Given this list of marker genes MIR181D, SH3RF1, MAP2K3, MAP2K6, KSR1, MAPK8IP3 (NCBI Gene Id 89855), ICAM1, MIR181B1, ADRA1B, FGF18, MINK1, MAP3K12, CRACR2A, DRD2, PLA2G1B, TPBG, FGF3, SASH1, FGG, MBIP, TENM1, PELI2, LYN, XIAP, UNC5CL, ANKRD6, WNT7A, ADRA2C, PLCG2, LTBR (lymphotoxin beta receptor), KLHDC10, FFAR4, TNIK, NOX1, SPRY2, ABCA7, C1QTNF1, MIR23A (microRNA 23a), TP73, MOS, NTF3, APOE, LPAR1, PDE6H, FGF4, TREM2, NRG1, ITGB3, GLIPR2, HTR2C, RB1CC1, RAMP3, NKD1, TRAF2, TLR4, NDST1, CHI3L1, CIB1, HLA-DRB1, MAP3K4, CTNNB1, FZD7, MIR519D, ZC3H12A, SHC1, EGFR, SH3RF2, CSF1R, GPNMB, S100A7, NOTCH2, TBX1, EDN3, GAS6 (NCBI Gene Id 2621), DNAJC27, MYD88, CDC42, LAT, MAP2K1, CCDC88C, EFNA1, MYOC, PLCB1, ACTA2, NOD1 (NCBI Gene Id 10392), ROCK2, SPAG9 (sperm associated antigen 9), DUSP19, TRAF6, FGFR1, C5AR1, SDCBP, PHB2, TLR6, DAB2IP, DVL3, CRK, IL1B (NCBI Gene Id 3553), INHBA, VEGFA, MIR92A1, TAOK3, KL, RAF1, MAPKBP1, F2RL1, HTR2A, ROBO1, CLEC7A, CCL3, CX3CL1, APELA, KSR2, GRM1, MYDGF, PDCD10, MIR21, RELL2, CD81, CCL21, CD44, IGF1R, SOD1, EGF, IGFBP3, BMPER (BMP binding endothelial regulator), FBXW7, RIPK2, DUSP15, PECAM1, TGFA, AKAP12, TNFRSF19, GNAI2, OPRM1, NRP1, BNIP2, ADAM9, CDH2 (cadherin 2), ADRB2, MAPK8IP1, IL6R, TGFB1, PIK3R5, SEMA4C, FGF23, FGF5, PRXL2C, NOTCH1, MAP3K5, TRAF4 (NCBI Gene Id 9618, TNF receptor associated factor 4), FCRL3, NODAL, IGF2, IGFBP4, MIR181A2, GFRAL, CRIPTO, MIR24-1, PROK1, RYK, FLT1, HTR2B, SLC30A10, MAP3K7, GPR37L1 (NCBI Gene Id 9283), GCNT2, CCN2, AVPR1B, FRS2, GPR55 (NCBI Gene Id 9290), RASGRF1, LGALS9, AVPI1, PRKCE, SPI1, LAPTM5 (lysosomal protein transmembrane 5), GHRL, NTRK2, NR2C2, FPR2, PLA2G5, LEP, FGF22, TRIM5, HAND2, LAMTOR2, TAB1, SYK, FGF21, BMP2, AGER, GH1, TIRAP, PDGFRB, EPO, VEGFB, CRKL, ROCK1, GADD45B, GPER1, ALKAL2, FGF20, MAPK8IP2, NENF, PDGFRA, MEF2C, CD74, TEK, FGF19, PRMT1, PIK3R6, ALOX12B, SRC, RASSF2, RAPGEF2, LPAR3, PYCARD, FSHR, NPNT, BCAR3, GSDME, NPY5R, MAP3K11, MTURN, OSM, FGFR3, NOD2, ELANE, AXIN1, MIR27A, ERBB3, FGF16, KLB, APP, CD36, ADRB3, FZD10, DIRAS1, PRKCA, IL26, ITGA1, ERBB2, ALOX15, FCGR2B, FGF10, SEMA3A, ZNF622, CFLAR, GPR183, PPIA, ANGPT1, TGFB2, LPAR2, SLCO3A1 (solute carrier organic anion transporter family member 3A1), MST1R, IL6, RELL1, NECAB2, FGF7, PTPN22, GCG, LRRK2, JAK2, LIF, ERP29, FGFR2, WNT4, S100A12, DHX33, ADRA2B, PDGFD, SERPINF2, FGA, PTPN11 (protein tyrosine phosphatase non-receptor type 11), CCR1 (NCBI Gene Id 1230), LILRA5, CCR7, PRKD2, SH3RF3, EPGN, WNT7B, CDK10, TAOK1 (TAO kinase 1), DVL2, NOX4, CSPG4, NTRK1, ADRA2A, HMGB1, MAP4K2, THPO, IQGAP1, FGF9, STK39, NDRG4, AR, TNFAIP8L3, MADD, SOX2, DUSP22, NMNAT1, WNT5A, DRD5, NRK, IL34, CXCL17, PTPN1 (protein tyrosine phosphatase non-receptor type 1), PRKCZ, IGFBP6, SEMA7A, DOK4, HCRTR1, MFHAS1, EDN1 (NCBI Gene Id 1906), TNFSF11, FLT4, DDR2, INSR, MARCO (macrophage receptor with collagenous structure), P2RY1, CD27, TNF, RNF13, TRAF7, FGF6, GADD45A, HAVCR2, MAPK3, TPD52L1, WWC1, INAVA, MIR27B, MAP2K7, JUN, FGF2, CALCR, IAPP, RASGRP1, TLR3, IL11, LAMTOR1, FGB (fibrinogen beta chain, NCBI Gene Id 2244), ERN1, WNT16, PRDX2, PDGFB, TMEM106A, MT3, DOK5, FLT3, DENND2B, GPBAR1 (G protein-coupled bile acid receptor 1), NELFE, BRAF (B-Raf proto-oncogene, serine/threonine kinase), BIRC7, ADRA1D, TRPV4, PTPRJ, EDA2R, ADAM8, KDR, SYT14P1, EIF2AK2, NAIP, EZH2, SCIMP, MAP3K3, PHB1, ACKR3, TLR9, ARRB1, INS, SLAMF1, NPY (neuropeptide Y), CAVIN3, TAOK2, EPHA8, SPHK1, JCAD, PDGFC, CCL19, RAP1A, GRM5, RAP1B, CDON, CARTPT, DRD1, MAP4K1, OR2AT4, FGF17, ARHGEF5, RIT2 (Ras like without CAAX 2), HGF, ARRB2, STK3, MAP3K10, HIPK2, PJA2 (praja ring finger ubiquitin ligase 2), GHR, DRD4, MIR126, BMP4, GAREM1, NPSR1, PLA2G2A, NTRK3, PDE6G, F2R, FGF1, IGF1, MIF, GPR37, LAMTOR3, PTK2B, DSC2, OPRK1, PDGFA, PTPRC, RET, PDE8B, GDF6, ADRB1, EDAR, CASR (calcium sensing receptor), ADORA2A, ADORA1 (adenosine A1 receptor), KIT, GDF15, EPHA4, GADD45G, CHRNA7, GRM4, PDE8A, ADCYAP1 (NCBI Gene Id 116), P2RX7, HRAS, ABL1, ARHGAP8, PIK3CG, FGFR4, FGF8, FERMT2, MIRLET7B, RIPK1, CAV2, MID1, CD4, ARL6IP5, CARD9, GPR101, BANK1, TNFRSF11A, DIRAS2, IQGAP3, STK25, DKK1, P2RY6, NGF, THBS1, DDT, NAMPT, ADRA1A, CD40, NEK10 (NIMA related kinase 10), NRXN1, ERBB4, SORBS3, ALKAL1, DSTYK, here is a description of the gene set: species: Homo sapiens Any process that activates or increases the frequency, rate or extent of signal transduction mediated by the MAPK cascade. Human Gene Set: GOBP_POSITIVE_REGULATION_OF_MAPK_CASCADE